The following is a description of a gene set: Genes up-regulated in memory CD8 T cells: ITGAE- from spleen versus ITGAE+ from brain. from publication Wakim LM, Woodward-Davis A, Liu R, Hu Y, Villadangos J, Smyth G, Bevan MJ (PMID 22922816) species: Homo sapiens Human Gene Set: GSE39152_SPLEEN_CD103_NEG_VS_BRAIN_CD103_POS_MEMORY_CD8_TCELL_UP Tissue resident memory (Trm) represent a newly described memory T cell population. We have previously characterized a population of Trm that persists within the brain following acute virus infection. Although capable of providing marked protection against a subsequent local challenge, brain Trm do not undergo recall expansion following dissociation from the tissue. Furthermore, these Trm do not depend on the same survival factors as the circulating memory T cell pool as assessed either in vivo or in vitro. To gain greater insight into this population of cells we compared the gene-expression profiles of Trm isolated from the brain to circulating memory T cells isolated from the spleen following an acute virus infection. Trm displayed altered expression of genes involved in chemotaxis, expressed a distinct set of transcription factors and overexpressed several inhibitory receptors. Cumulatively, these data indicates that Trm are a distinct memory T cell population disconnected from the circulating memory T cell pool and displaying a unique molecular signature which likely results in optimal survival and function within their local environment., and this is the list of marker genes: UBAC2, PRKD1, PLA2G5, SH3BP5, ABCF2, RUNDC3A, TNFRSF18, SERPINH1, KIF3B, ATXN1, H1-6, RAB4B, TUBB4B, LTBP2, PTPN11, KRTDAP, EXOSC8, GNPTAB, DNAJC7, IL12RB1, ST3GAL2, LRWD1, ATP1B1, SYT11, COL8A1, BTD, GPR37L1, ZSWIM1, PLD3, COMT, HMOX1, CIC, EEF2, FERMT3, SPARCL1, WDR48, RHO, ARF3, NEXMIF, C1QA, FAM110A, C2CD2, INHA, RRAD, ABCC6, MTREX, TECTA, TIMP1, FAU, TBR1, LTB4R, CD99, ABCA1, EFNA3, UBE2M, VPS51, SLC10A1, AUP1, ASAP1, UBAC1, ATP13A2, SPART, GJB5, TMEM45A, TBC1D10A, ZSCAN2, CAPZB, LHX1, AQP7, MAPK3, PHKG2, HGF, BET1, ARFIP2, UBE2I, MATN2, TTC14, SPDEF, GATA2, IL17D, APP, COL17A1, SLC1A1, CBX6, KARS1, METTL18, VAX1, CAB39L, MRPS18A, SLC25A48 (solute carrier family 25 member 48, NCBI Gene Id 153328), FGF11 (fibroblast growth factor 11), FBXL12, GALNT2, TIPARP, ARHGEF2, CSTF1, UCP3, INPP5D (NCBI Gene Id 653796), ZBTB2, TMT1A, ALKBH5, EEF1B2, IFNAR1, GTF2I, PARN, SSBP4, HMGA1, EN1, RNF26, SMPD1, CLPX, PHRF1, MZT2B, CHRND, PSMD3, TGFBI, C6orf136, TMEM259, TSPAN4, SERPINA10, ACOX1, CLIP3, HOXC8, AP1B1, ICAM5, RAMP3, SLC25A36, BMP8B, CSNK1D, GPR132 (G protein-coupled receptor 132, NCBI Gene Id 29933), PIAS1, KLF3 (NCBI Gene Id 51274), CTSC, INPP4A, GCK, FABP5, RIMKLB, CCL22, B4GALNT2, CD247, DAPK3, PTGIR (prostaglandin I2 receptor), PIK3C2A, NFATC1, LDHB, SCAMP3, PTPRN, TWF2, VAV1, CD151, UPK2, KRT86, GPAA1, HSD17B7, C9orf72, LPP, IFT70B, PIK3C2G (phosphatidylinositol-4-phosphate 3-kinase catalytic subunit type 2 gamma), MUC1, TMPRSS15, RHOA, COL4A2, NCF1, CAND1, PTPRE, ARHGAP39, NUDC, ATP8A1, PROM1, CPS1, CLTC, CHFR (NCBI Gene Id 56732), TIMM10B, SOAT2, TRAPPC3, EIF4B, USP5, PRPS2, GCNT1 (NCBI Gene Id 2650), WBP1, NSMCE1, APBA3, HLA-DMB, AAMP, ACOT8, MAFB, BMP7, SEC61A1 (SEC61 translocon subunit alpha 1), APLP1, FBXW11, DOK1, PTPN1, ENSA, RBM6, SH2B3, REL, EYA1, RAB8B, LHB, ASB6